The following is a description of a gene set: part of: Resolution of AP sites via the multiple-nucleotide patch replacement pathway studied in species Homo sapiens During POLB-dependent long patch base excision repair (BER), PARP1 and/or PARP2 is recruited to the BER site along with flap endonuclease FEN1. PARP1 and/or PARP2 and FEN1 facilitate POLB-mediated strand displacement synthesis which involves incorporation of 2-10 nucleotides at the 3' end of the APEX1-created single strand break (SSB). After the DNA strand displacement synthesis is completed and the displaced strand is cleaved, POLB recruits DNA ligase I (LIG1) to ligate the SSB. Reactome Pathway: POLB-Dependent Long Patch Base Excision Repair, and this is the list of marker genes: APEX1, LIG1, ADPRS, POLB, PARP1, FEN1, PARG (NCBI Gene Id 95267), PARP2